Given this list of marker genes VPS16, TMEM216, SPG11, OFD1, SIX6, TOPORS, BRAF, TCTN3, LEPR, SOX2, CDH2, FAM149B1, GLI3, KIAA0753, SMO, CTNNB1, KIF7 (kinesin family member 7), TMEM231 (transmembrane protein 231), CPLANE1, TIAM1, PDE6D, MAN2C1, here is a description of the gene set: Abnormal hypothalamus morphology Human Gene Set: HP_ABNORMAL_HYPOTHALAMUS_MORPHOLOGY species: Homo sapiens Any structural anomaly of the hypothalamus.